The following is a description of a gene set: Mouse Gene Set: chr15B3 studied in species Mus musculus, and this is the list of marker genes: Gm8668, Angpt1, Gm25007, Ebag9, Gm23530, Gm2333, Zfpm2, 1100001I12Rik, 4930413F20Rik, Gm26766, Gm3267, Gm9509, Gm23848, Gm6704, Gm46515, Gm34150, Mtdh, Gm41311, Ubr5, Eif3e, Atp6v1c1, Rnf19a, Laptm4b, Mir6951, Gm7508, Gm2267, Gm10384, Lrp12, Gm41318, Abra, Gm26063, Snord123, Tas2r119, Mir599, Vps13b (vacuolar protein sorting 13B), Gm10373, Gm7517, Gm35248, Mir875, Gm25093, Fbxo43 (F-box protein 43), Cpq, Gm18531, Osr2, Pop1, Gm7968, Gm32618, Gm19235, 9430069I07Rik, Gm23185, Cox6c, Klf10, Pkhd1l1, 9930017N22Rik, Gm41300, Gm16291, Gm41289, Rrm2b, Gm16136 (predicted gene 16136), Gm9643, Rgs22, 4930518I17Rik, Gm16138, Fzd6, Gm8705, Gm41293, Gm9658, Tmem74, Gm23754, Azin1, Gm9501, Ncald, Gm15942, 4921515G04Rik, Tspyl5, Dcaf13, Gm23665, Gm23343, Gm10385, Gm45924, D730044K07Rik, Gm33497, 4930548G14Rik (NCBI Gene Id 75281), Gm35167, Gm24751 (NCBI Gene Id 115485997), 4930465K09Rik, Csmd3, Gm26854, Gm17473, Gm18889, Gm5471, 9130002K18Rik, Snhg18, Gm4740, Emc2, 2310043O21Rik, Gm24523, Gm22353, Gm34590, Gm5472, 4930555K19Rik, Gm16300, Gm24771, Gm18153, Gm3362, Erich5, Gm16294, Matn2, Kcns2, 4930523O13Rik, Gm22208, Gm7459, Pabpc1, Odf1, Sema5a, Gm7382, Rspo2, Gm18949, 4930447A16Rik, G930009F23Rik, Gm5213, Gm2203, Gm5469, Nipal2 (NIPA-like domain containing 2), Gm41290, Gm9522, Rps19-ps5, Sdc2, Gm8664, Siah1-ps2, Sybu, Spag1, AU022793, Gm2140, Gm24833, Nudcd1, Slc25a32, Zfp706, Mir8097, Gm33936 (NCBI Gene Id 102637024), Ywhaz, 9330182O14Rik, Gm49085, Rims2, Rida, Gm5470, Cthrc1, Gm22979, Rpl7a-ps3, Stk3, Gm24903 (predicted gene, 24903), Gm18092, Trhr, Grhl2, 4930592A05Rik, Dpys, Gm26704, Gm24789, Polr2k, Gm29697, BC048602, Kcnv1, Eny2, Rpl30, Gm15941, Oxr1, 1700022A22Rik, Dcstamp, Gm32764, Baalc, Gm18994, Gm38541 (NCBI Gene Id 102641202), Gm34093, 1700084J12Rik, Gm35019, Ankrd46, Snx31, Gm49186